The following is a description of a gene set: species: Homo sapiens Any process that stops, prevents, or reduces the frequency, rate or extent of oligodendrocyte differentiation. Human Gene Set: GOBP_NEGATIVE_REGULATION_OF_OLIGODENDROCYTE_DIFFERENTIATION, and this is the list of marker genes: ID2, CTNNB1, NOTCH1, NF1, DLX1, HES5, HES1, TMEM98, ID4, DUSP10, DRD3, DAAM2, NKX6-1, NKX6-2, DLX2